Given this list of marker genes FSTL4, SEMA4D, PTPRS, RND2, SPP1, NGF, RGMA (NCBI Gene Id 56963), SPART, BCL11A, ULK1 (NCBI Gene Id 8408), CRABP2, BDNF, IFRD1, WNT3A, LPAR3, ULK2, FGF13, EFNA5, IST1, EPHA7, WNT3, DCC, here is a description of the gene set: Human Gene Set: GOBP_REGULATION_OF_COLLATERAL_SPROUTING Any process that modulates the frequency, rate or extent of collateral sprouting. studied in species Homo sapiens